The following is a description of a gene set: Mouse Gene Set: GOBP_POSITIVE_REGULATION_OF_NATURAL_KILLER_CELL_PROLIFERATION Any process that activates or increases the frequency, rate or extent of natural killer cell proliferation. studied in species Mus musculus, and this is the list of marker genes: Jak2, H2-T23, Il12b, Tyk2, Stat5b, Il18, Il23a, Il15, Flt3l, Cd244a